Given this list of marker genes Tnrc6b, Ranbp2, Ndc1, Pom121, Nup188, Ipo8, Ago3, Nup160, Nup88, Nup210, Nup62, Ran, Nup214, Nup133, Nup85, Nup153, Nup43, Rae1, Nup50, Sec13, Nup54, Nup93, Nup205, Tsnax, Seh1l, Ago2, Tpr, Nup42, Nup35, Tnrc6a, Nup155, Ago1, Tsn, Nup107, Aaas, Tarbp2, Nup37, Nup98, Prkra (protein kinase, interferon inducible double stranded RNA dependent activator), Nup58, Ago4, here is a description of the gene set: Gene Silencing by RNA studied in species Mus musculus Mouse Gene Set: REACTOME_GENE_SILENCING_BY_RNA